The following is a description of a gene set: Subependymal cysts Cerebral cysts, usually located in the wall of the caudate nucleus or in the caudothalamic groove. They are found in up to 5.2% of all neonates, using transfontanellar ultrasound in the first days of life. species: Homo sapiens Human Gene Set: HP_SUBEPENDYMAL_CYSTS, and this is the list of marker genes: GLUL, PEX1, TXN2, TUBGCP2, AHDC1, PLCH1, RRAGC, D2HGDH, PDHX